Given this list of marker genes CHTOP, BRD9, TAF9B, MTMR4, USP9X, CASP2, ASB3, ZNF84, UBR7, SMAD7, UPF3A, FAN1, DFFA, RBM25, CHD9, U2SURP, INTS5, ATG2B, TEFM, SH2B1, IQCK, ISCA1, MOB4, CLK4, KAT6B, TRAPPC14 (NCBI Gene Id 55262), MTPN, CREB1, TBC1D10B, PTCD3, KDM3B, CLEC16A, UBE2N, MICU1, DDX47, EPM2AIP1 (EPM2A interacting protein 1), ZNF286A, ING4, SPECC1L, TIA1, FNTB, SUFU, TARDBP, NUMA1, MAEA (macrophage erythroblast attacher, E3 ubiquitin ligase), HAPSTR1, JKAMP, EPC2, TUBGCP4, TTC17, ASCC1, NAA25, TNPO2, VPS53, DYNC1I2, ERG28, ZNF384, POGZ, SMG1, ZNF292, IPO9, BPTF, NSUN5P1, NF2, CELF1, PRRC2B, BAZ2A, ZNF529, IDH3G, ATG4B, DHX36, RBM4B, AAAS, GFM2, HNRNPH3, USP33 (ubiquitin specific peptidase 33), CS, ANKRD12, BOD1L1, RIMOC1, MSL1, ANKRD10, TMEM106B, SIN3A, NFYA, SLC41A3, MED17, ZBED1, CRAMP1, PATL1, ZMIZ1, SENP7, TNPO1 (NCBI Gene Id 3842), EXOC5, BAHD1, AARS2, ZNF512, TEX261, TRAPPC6B, HGS, APBB3, TUT1, IPO5, USP19 (NCBI Gene Id 10869), ZNF274, LINC01278, CHAMP1, MTMR3, NUP133, COMMD9, TMEM245, CREBRF (CREB3 regulatory factor), DENND4A, PRDM4, OTUD6B, OCIAD1, RABL2B, TBCK, ACTR10, PACS2, PRPF8, LUC7L3, RPL7L1, PCF11, KHDC4, FBXL20, CNOT6, ZBTB22, KLHL11, WDR70, CNPPD1, SLC35E2A, ABHD16A, WDR19, MARCHF7, MEPCE, RBM8A, TTC14, PAFAH1B2, LEMD3, C2CD5, CSRNP2, ZFAND5, C1orf52, METTL17, ZNF644, PRKRA (protein activator of interferon induced protein kinase EIF2AK2), THUMPD1, PHF2, PGRMC2, NXF1, MTMR7, ZNF212, RABGEF1, KMT2A, VPS26B, FOXO3, GPBP1, SAFB, HNRNPR, CUL5, SAP130, FAM168B, PKNOX1, NCOA5, ATOSA, GSPT1, PPIG, MORF4L1, TBC1D22B, ANKRA2, RNF8, SLC25A29, COQ10A, here is a description of the gene set: species: Homo sapiens Human Gene Set: GCM_MLL Neighborhood of MLL Neighborhood of MLL myeloid/lymphoid or mixed-lineage leukemia (trithorax homolog, Drosophila) in the GCM expression compendium